Given this list of marker genes TBX5, IQSEC2, FGFR1, EPM2A, MFAP5, OCM, MSRB2, RPE, FAM222A, TMEM100, CMTR1, ATP2B2, DHFR, SPTBN1, HDGF, CRNKL1, SALL3, SLC66A1LP, GLYATL2, OCM2, C6orf89, YIPF1, USP14, CD37, NRG3, RAB27B, DOCK7, EXOC3L2, TNPO3, GEMIN5, NTS, QKI, SLC35E2A, KSR2, SUOX, HSD17B4, ZNHIT1, BEST1, OSBPL1A, LIPA, ETFRF1, CAMK2D, ADH6, TYRO3, PHLDB2, PRPF38B, ZNF607, ZCCHC17, MPDU1, FLI1, DUOX1, here is a description of the gene set: Genes predicted to be targets of miRBase v22 microRNA hsa-miR-4701-3p in miRDB v6.0 with MirTarget v4 prediction scores > 80 (high confidence targets). Human Gene Set: MIR4701_3P species: Homo sapiens from publication Chen Y, Wang X (PMID 31504780)